The following is a description of a gene set: Genes up-regulated in comparison of B cells versus myeloid dendritic cells (mDC). Systems vaccinology has emerged as an interdisciplinary field that combines systems wide measurements and network and predictive modeling applied to vaccinology. Here we used the systems vaccinology approach to study the molecular mechanisms underlying th Human Gene Set: GSE29618_BCELL_VS_MDC_UP species: Homo sapiens from publication Nakaya HI, Wrammert J, Lee EK, Racioppi L, Marie-Kunze S, Haining WN, Means AR, Kasturi SP, Khan N, Li GM, McCausland M, Kanchan V, Kokko KE, Li S, Elbein R, Mehta AK, Aderem A, Subbarao K, Ahmed R, Pulendran B (PMID 21743478), and this is the list of marker genes: SNRNP70, VAT1, ZHX2, ABLIM1, RUBCNL, SYNPO, CTC1, HECA, LBH, CYFIP2, ISG20, MAP4K4, TAF1D, YTHDC1, RHOH, CR1, RAB30, HMGB2, TNFRSF13B, TPD52, CLMN, TSPYL1, LUC7L, ISCU (iron-sulfur cluster assembly enzyme), CXCR5, IGLV1-44, PALS2, IL4R, SP140, STAG3, ZNF430, ADAM19, PHF3, ARHGAP24, PIK3C2B, ELL2, GRK5, BACH2, ARHGAP25, JAM3, PELI1, OPTN, BANK1, RIPOR2, BBIP1, EZR, NCK2, KCNA3, KLF7 (KLF transcription factor 7), PHTF2, ADD2, IGLJ3, WASHC4, CDK14, RMC1, PCDH9, GABPB1, ADD3, PIKFYVE, TRBC1, LAMC1, BTG1, STAP1, DMXL1, KLF2 (NCBI Gene Id 51713), MCTP2, CD19, P2RY10, FCRL2, SMCHD1, TMEM243, NCF1C, PIK3IP1, TUBA4A, NUP88, CD72, PPP3CC, IL24, FAM3C, PLCG2, COBLL1, SGCE (sarcoglycan epsilon), IGLV3-19, SHOC2, ATP2A3, PIM2, LY9, AIM2, PNRC1, SNX2, IKZF3, ZNF107, TSC22D3, USP6NL, EIF1B, ARID5B, ZNF43, STK17A, CDC25B, CHMP7, PRDM2, IGHM, PWP1, PAX5, CKAP2, ST6GAL1, POU2AF1, ZFP36L2 (ZFP36 ring finger protein like 2), TENT5C, CD79B, ZNF253, CD22, TXNIP, RYK, CSNK1G3, NOC3L, HLA-F-AS1, SYPL1, TSPAN3, GVINP1, P2RX5, ADAM28, GOLGA8A (NCBI Gene Id 23015), CD24, MTSS1, RASGRP2, E2F5, IGHD, RESF1, EGR1, BMS1P20, AQP3, RASGRP3, MXI1, FCER2, BIRC3, ZNF395, MS4A1, PKIG, SPTBN1, ETS1, BACE2 (beta-secretase 2), BLK, CD79A, CLEC2D, CHD7, ITPR1, S1PR1, IFT57, EIF4A2, CD81, RBM5, TCL1A, CCR7, AFF4, WWC3, CD47, LTB, PDCD4, FOXO1 (NCBI Gene Id 2308), EIF5, TTC9, MYC, EIF2AK3, SWAP70, CHST15, PLEKHA2, GGA2, ODC1, PNOC, GPR18, IGLL3P, RRAS2, IGKV3-20, TERF2IP, CD37, NT5E, IGKC, PRKD2, OPHN1, TSPAN13, TLE1, IGHG1, PIP5K1B, IGKV4-1, PTPRCAP, TOP6BL, MARCHF3 (NCBI Gene Id 153277), FAM30A, RASGRP1 (RAS guanyl releasing protein 1), FCHSD2, CBLB, KMT2A, OGA